Given this list of marker genes Psma5 (NCBI Gene Id 26442), Stx3, Ccl24, Cmpk1, Max, Gls, Hnrnpf, Iigp1, Serpina3g, Ifi204, Cish, Ifi205, Cxcl9, Nrg1, Tcerg1, Srgap2 (NCBI Gene Id 98351), Jpt1, Irgm1, Coro2a, Ffar2, Ube2l6, Srsf7, Ifitm1, Spcs2, Ms4a6d, Znhit1, Txn1, Eps8, Gatm, Stk19, Hspa8, Cyrib, Pnp, Ifi47, Tuba1b, Batf3, Nop58, Gda, Gbp4, Ctsz, Sec63, Aig1, Tap1, Pkib, Niban2, Socs1, Cndp2, Fcgr1, Gbp3, Eif4a1, Timm9, Naa20, Morf4l2, Mrpl35, H2-DMa, Batf2, Klrk1, Bak1, Noc4l, Gbp5, Gbp9, Uckl1, Psmb10 (proteasome (prosome, macropain) subunit, beta type 10), Magohb, Nsd2, Naaa, Tfec, Ly6a, Psma3, Irgm2, Glrx, Prpf38a, Tes, Tmem214, Isg15, Ctsc, Snx2, Mrps15, Cmklr1 (chemerin chemokine-like receptor 1), Daxx, Pim1, Tsfm, Fcgr4, Slamf8, Bop1, Naa25, Ap3s1, Dok2, Atf1, Cnn3, Ccr5, Fgl2 (NCBI Gene Id 14190), Dnajb11, Bst1, Vdac2 (NCBI Gene Id 22334), Sdc4, Srgn, Llph, Psme2, Skap2, Ltb4r1, Irf8, Ciita, Gbp8, Gbp7, Psmb8, Man2a1, Irf1, Selenos, Sod2, Fryl, Clcn7, Ube2d3, Srsf3, Tgm2, Hhex, Rmdn3, Lap3, Tnfaip2, Flot1, Igtp, Ralgds, Nab2, Macroh2a1, Ifi209, Slc15a3, Ccdc86, Cd164, Scimp, Ggct, Cxcl10, Calr, Vcan, St7, Stx11, Oxct1, Tap2, Tarm1, Ppp1r14b, Slfn2, Cops5, Atp6v0a1, Sumo2, Zbp1, Cd40 (NCBI Gene Id 98930), Gbp2, Nampt, Atp11a, Arl1, Stat1, Ifi211, Arf1, Calhm6, Adap2 (NCBI Gene Id 216991), Dram1, Ccr1, Mgat2, Tcp1, H2-T23, Samhd1, Bcl2a1d, Cd300lf, Ppa1, Arhgap31, Hspa5, Pfkp, Ifi35, Lilrb4b, Rbpj, Vapa, Htt, Arap2, Creld2, Eif2s3x, Parp14, Tpm3, Ccdc25, Rab44, Cggbp1, Rars1, Psmb9, Manf, Fcgr3, Sdad1, Ccl12, Fam241a, Tigd2, Cd274, BC031181, Vps37b (vacuolar protein sorting 37B), Msr1, Hif1a, Eif2s1, Sdcbp, Slfn1 (schlafen 1), Psmd14, Stxbp3, here is a description of the gene set: from publication Cui A, Huang T, Li S, Ma A, Pérez JL, Sander C, Keskin DB, Wu CJ, Fraenkel E, Hacohen N (PMID 38057668) Mouse Gene Set: CUI_MONOCYTE_IL18_RESPONSE_UP studied in species Mus musculus Cytokines mediate cell-cell communication in the immune system and represent important therapeutic targets. A myriad of studies have highlighted their central role in immune function, yet we lack a global view of the cellular responses of each immune cell type to each cytokine. To address this gap, the authors created the Immune Dictionary, a compendium of single-cell transcriptomic profiles of more than 17 immune cell types in response to each of 86 cytokines (>1,400 cytokine-cell type combinations) in mouse lymph nodes in vivo. A cytokine-centric view of the dictionary revealed that most cytokines induce highly cell-type-specific responses. For example, the inflammatory cytokine interleukin-1β induces distinct gene programmes in almost every cell type. A cell-type-centric view of the dictionary identified more than 66 cytokine-driven cellular polarization states across immune cell types, including previously uncharacterized states such as an interleukin-18-induced polyfunctional natural killer cell state. Genes positively differentially expressed in cell type: Monocyte upon treatment with cytokine: IL-18 in mouse lymph nodes in vivo.